The following is a description of a gene set: A cyanobacterial LPS antagonist prevents endotoxin shock and blocks sustained TLR4 stimulation required for cytokine expression. We report the identification and biologic characterization of an LPS-like molecule extracted from the cyanobacterium Oscillatoria Planktothrix FP1 (CyP). studied in species Homo sapiens Genes up-regulated in monocyte-derived dendritic cells: LPS like antigen from O. planktothrix (3h) versus LPS and LPS like antigen from O. planktothrix (3h). Human Gene Set: GSE4748_CYANOBACTERIUM_LPSLIKE_VS_LPS_AND_CYANOBACTERIUM_LPSLIKE_STIM_DC_3H_UP from publication Macagno A, Molteni M, Rinaldi A, Bertoni F, Lanzavecchia A, Rossetti C, Sallusto F (PMID 16717116), and this is the list of marker genes: KBTBD8, PCDH9, CD83, RFTN1, QRSL1, CCDC28B, FOXO1, AARS1, SERPINB9P1 (NCBI Gene Id 221756), POLE3, NCL, NDC1, DIP2C, AGPAT5, CSNK2A1, PAX5, IGHV5-78, EEF2K, NAA40, P2RX5, SLC25A36, IGKV4-1, TIMELESS, THEM4, JCHAIN, IGHD, NACA2, RPL28, ZNF80, DNAAF10, MZB1, SHMT2, F2R (NCBI Gene Id 2149), IGHM, TAPT1, HIRIP3 (HIRA interacting protein 3), HS3ST3B1, NAP1L1, UBA2, CNKSR2, CD22, AIMP2, ALKAL2, DTX1, NIP7, IGKV3-20, SH2D1B, IRGM, HTT, MCRIP1, NOC3L, TKTL1, RPLP1, LRIG1, HLA-DOB, SPIB, IGKC, TRMT10A, RP9P, IGLV1-44, NFATC3, XBP1 (X-box binding protein 1), RASGRP3, SIDT1, LARP4 (NCBI Gene Id 113251), PLEKHA1, IGKV1D-13, SH2D2A, RGS1, PRKCE, PYROXD2, CCL23, POLR2D, KCNH8, SPATA9, NF2, DENND2D, SNX9, MTSS1, RUNX1, CD247, FCER2, MEOX1, PRF1, DPP4, CD79A, MRPS35 (mitochondrial ribosomal protein S35), UFM1, TMED10, CORO2B, RPUSD2, TXK, SCN3A, FCRLA, ZNF275, PPP1R17, TSPYL5, ANAPC5, FCRL5, IRF8, RTKN2, CD72, TSEN54, ADARB1, SMIM30 (NCBI Gene Id 402587), IGLV3-19, GUSBP11, SLC2A11, BCL11A, CXCR5, CBX5, HMCES, FCRL1, CHD1L, FANK1, TET1, UBL7-DT, INO80, CD79B, ZBTB5, MACROD2, GZMB, DDX51, BACH2, ARL4C, ZCCHC17, YES1, ERMP1, ST8SIA1, CLLU1 (NCBI Gene Id 574028), NEFL, TRIM44, NIBAN3, IGLL3P, TMEM229B, BANK1, ZNF264, TMPO, TBRG4, PIK3C2B, RPLP0, EFCAB14, ZNF30, MEF2C, TNFRSF17, POMGNT1, SPDL1, CCDC127 (NCBI Gene Id 133957), ZNF141, TSPAN3, POLR1C, EIF2B2, CXXC5, PTPRK, WDR4, ATF7IP2, SNX25, EBF1, FCMR, PARP1, BLK, TMEM41A, STAP1, CENPL, RBFA, CCDC66, WASF1, WDR74, AFF3, BTLA, POLR3GL, ABCB4, ADO, NCR3 (NCBI Gene Id 91958), ZBTB16, UICLM, TSPAN13, SS18L2, PNOC, PLPP5, MIR600HG, ARID5B, BLNK, IGLJ3, RBL1, CD200, LAX1, AKR1C3, ENPP2, HNRNPR, ZNF677, FBXO25, IL2RB, PMEPA1